The following is a description of a gene set: Mouse Gene Set: GOBP_LIPID_DROPLET_FUSION studied in species Mus musculus The process by which a single lipid droplet is created from the fusion of two or more lipid droplets., and this is the list of marker genes: Pnpla2, Cidec, Ldah, Clstn3 (calsyntenin 3), Cidea, Cideb